The following is a description of a gene set: Nlrp10-deficient mice have a profound defect in helper T cell-driven immune responses. T cell priming is impaired due to a defect in the emigration of a dendritic cells from inflamed tissue and antigen transport to draining lymph nodes. DC chemotaxis to CCR7-dependent and independent ligands is intact in the absence of Nlrp10. Therefore to identify novel molecules potentially involved in Nlrp10-dependent DC function we used an unbiased gene array approach on Nlrp10-deficient BMDCs treated with or without LPS. from publication Eisenbarth SC, Williams A, Colegio OR, Meng H, Strowig T, Rongvaux A, Henao-Mejia J, Thaiss CA, Joly S, Gonzalez DG, Xu L, Zenewicz LA, Haberman AM, Elinav E, Kleinstein SH, Sutterwala FS, Flavell RA (PMID 22538615) Genes down-regulated in dendritic cells with knockout of NLRP10: control versus LPS. Human Gene Set: GSE36009_UNSTIM_VS_LPS_STIM_NLRP10_KO_DC_DN studied in species Homo sapiens, and this is the list of marker genes: PRF1, DDX46, KIF3A, USE1, TASL, ECPAS, RPRD1B, CD2AP, POLR1C, ANKRD23, TFAP2B, LHCGR, EID2, H2BC18, ADI1, RFC1, GPN1, NEURL4, ZNF777, ATP6AP1, EARS2, MTHFD2, AKIP1, TBL1X, CIAO3, PPP2R5A, MAMDC4, CXXC1, MACROH2A1, MVK, EYA2, MRPL19, MRPL47, AKR7A2, FGF7, TUBA1B, SH2B1, ERN1, RAB3IL1, NDUFAF4, PPP4R3B, MRPS34, SMR3A, EXOSC1, GRWD1, YME1L1, ZFAND5, TRAPPC8, CCT8L2, MAK16, CHURC1, AK2 (NCBI Gene Id 83165), ARFRP1, SESTD1 (SEC14 and spectrin domain containing 1), RCL1, TTL, HIPK1, SS18L2, C1orf122, ETNK1, PIP5K1A, IL31RA, PLEKHF1 (pleckstrin homology and FYVE domain containing 1), TGM3, ABHD11 (abhydrolase domain containing 11), ARID2, RPS8, CLDN19, PTK2, SRPX2, TMT1A, SKAP1, SASH1, PTRH1, FMR1, GPRC5C, RPS19, CNIH1, ACACA, NUP37, RPAIN, ACBD3, SMPD4, ANKRD11, MSMB, TTC14, PSMA7, SIT1 (signaling threshold regulating transmembrane adaptor 1), CDKL3, RBM5, RTCB, CDK6, FHIP1B, SUCLG1, LYAR, FOXK1, PSMC2, DIPK1A, UBN2, PML, RANBP1, CLK4, KAT14, ZBTB43, LHFPL3, PPP3CC, FXYD7, LAPTM5, SPPL2B, BDH1, NUFIP1, MESD, SPRING1 (SREBF pathway regulator in golgi 1), BCLAF1 (NCBI Gene Id 9774), UNC119B, FHOD3, CCND1, NOP10, DNASE1, CNOT8, WDR46, BARHL2, RINL, SLFN12, AGA, FOLR2, BCL2A1, CLEC10A (NCBI Gene Id 10462), ZNF410, PRKD3, ATP11C, ERCC3, CCNT2, RPA1 (replication protein A1), STK17B, GPN3, MMUT, NEMF, BAZ1A, KCNQ1OT1, NECAP1, RACK1, PLEKHJ1, FYB1, SLC16A1, GINM1, FASTKD1, GPATCH4, HSPA9, PES1, LRIG1, LIMS4, USP31, LRRC75B, NOP56, PTPN11, MRPL28, SKP1, CHEK1, ADRA2C, PCNT, CD44, CCDC91, IARS1, VPS37B, SMPD5, WDR89, MATN4, ATF4, PEX5, CPNE1, NELFB (NCBI Gene Id 25920), BCAT2, NOL11, RRS1, DRC1, TEX9, DNAJA1, KCTD3, REV3L, ATP5MC2, PANX3, LMO1, NFE2L2 (NFE2 like bZIP transcription factor 2), PFDN5, KLK8, NDOR1, RUNX3, RPS6KB1, RECK, CRYBG1, MRPL12, RARS1, NOB1 (NIN1 (RPN12) binding protein 1 homolog), SYNJ1, EIF4A2, IFIT3, RPS6KB2